Given this list of marker genes TRMT61A, CMTR2, TRMT61B, METTL3, NSUN4, METTL1, CMTR1 (cap methyltransferase 1), PCIF1, METTL8, METTL16, METTL14, NSUN2, TMT1A, RNMT, here is a description of the gene set: Human Gene Set: GOMF_MRNA_METHYLTRANSFERASE_ACTIVITY Catalysis of the transfer of a methyl group from S-adenosyl-L-methionine to a nucleoside residue in an mRNA molecule. species: Homo sapiens